The following is a description of a gene set: studied in species Homo sapiens Human Gene Set: GOBP_POLYPRENOL_METABOLIC_PROCESS The chemical reactions and pathways involving polyprenols, prenols with more than 4 isoprenoid residues, which may be all-trans, or a mixture of cis and trans., and this is the list of marker genes: DPM2, DPM3, DPM1, DHRSX, AKR1B10, SRD5A3, DHDDS, AKR1C3, NUS1, DOLK (dolichol kinase)